The following is a description of a gene set: species: Mus musculus Mouse Gene Set: REACTOME_CYTOSOLIC_SULFONATION_OF_SMALL_MOLECULES Cytosolic sulfonation of small molecules, and this is the list of marker genes: Sult1a1, Sult1b1, Sult4a1, Sult2a2, Bpnt2, Papss2 (3'-phosphoadenosine 5'-phosphosulfate synthase 2), Sult1c2, Sult6b1, Abhd14b, Slc35b3, Sult1e1, Sult2b1, Tpst1, Podxl2, Slc35b2, Sult2a1, Slc26a1, Slc26a2, Bpnt1, Tpst2, Papss1